Given this list of marker genes SLC35A3, SLC35D3, SLC35A1, SLC35E3, SLC35C1, SLC35D2 (NCBI Gene Id 11046), SLC35A5, SLC35A4, SLC35B4, SLC35A2, TMEM241 (NCBI Gene Id 85019), SLC35D1, SLC35B1, here is a description of the gene set: Human Gene Set: GOMF_NUCLEOTIDE_SUGAR_TRANSMEMBRANE_TRANSPORTER_ACTIVITY species: Homo sapiens Enables the transfer of a nucleotide-sugar from one side of a membrane to the other. A nucleotide-sugar is any nucleotide in which the distal phosphoric residue of a nucleoside 5'-diphosphate is in glycosidic linkage with a monosaccharide or monosaccharide derivative.